The following is a description of a gene set: studied in species Homo sapiens from publication Chaussabel D, Semnani RT, McDowell MA, Sacks D, Sher A, Nutman TB (PMID 12663451) Monocyte-derived dendritic cells (DC) and macrophages (MΦ) generated in vitro from the same individual blood donors were exposed to five different pathogens, and gene expression profiles were assessed by microarray analysis. Responses to Mycobacterium tuberculosis and to phylogenetically distinct protozoan (Leishmania major, L. donovani, Toxoplasma gondii) and helminth (Brugia malayi) parasites were examined, each of which produces chronic infections in humans yet vary considerably in the nature of the immune responses they trigger. Human Gene Set: GSE360_LOW_DOSE_B_MALAYI_VS_M_TUBERCULOSIS_DC_DN Genes down-regulated in comparison of dendritic cells (DC) exposed to 5 worms/well B. malayi versus DC exposed to M. tuberculosis, and this is the list of marker genes: BRD4, BIRC3, FCGR3B (Fc gamma receptor IIIb), CCT2, PPP2CB, YKT6, H2BC21, ADAR, PLAUR, LDHA, ICAM1, NPRL3, SSB, PLSCR1, GNA15, RALA, LCP1, HSPA5, ANKRD12, OAS2, RBCK1, TNIP1, RND3, ADGRE1, IER3, KYNU, FLT1, MAD2L1BP, CD27, MT1B, GNRH2, CRHR2 (NCBI Gene Id 1395), RFTN1, DENND5A, MX2, UBE2S, MPZL2, ATP2A2, PLA2G7, MMP9, MPDU1, N4BP1, MT1G, TUBB2A, WIPI1, CXCL5, TNFSF14, TRIM38, CCL25, CDK3, DYNLL1, TSPOAP1, HSPA1A, TYMP, MAP2K3, CD47, NRP2, RHBDF1, PEX1, PDE4D, LY6E, RNASE4, NDRG1, PPP1R15A, HBEGF, VAMP5, PRRG1, CUL1, SQLE, PDPN, IFRD1, IFIT2 (interferon induced protein with tetratricopeptide repeats 2), CD48, RIT1, RAPGEF2, ATP6V0E1, SMURF2, DHFR, RRBP1, AASS, SLC22A4, WTAP, CDC42, AK4 (adenylate kinase 4), GPC4, HSPA8, LHFPL2, IL2RG, CCL3 (C-C motif chemokine ligand 3), DTX4, MT2A, S100A8, IL2RA, BASP1, PSMD2, TRIP10, LCP2, CCR7, APBA3, C3AR1, TXN, DENND3, BCL2A1, ALDH1A2, GPD2, CDH1, CCRL2, IL10RA, RBM14, ATF3, GBP2, TSFM, CCL2, PNP, NME1, STOM, MARCO, SLAMF1, CRIM1, INHBA, TFIP11, ELL2, IFI44, SPINK4, BST2, OASL (2'-5'-oligoadenylate synthetase like), SH3BP5, CASP5, AMHR2 (NCBI Gene Id 269), CETN2 (centrin 2), SLC31A1, DUSP1, MYD88, MT1X, CD83, CTSL, CYBB, FSCN1, FANCL, ALAS1, PIM1, GMPR, PFKFB3, RRH, LTK, CYB5A, GJB1, BAZ1A, WARS1, RER1, PLXNC1 (plexin C1), PSMA3, TRAFD1, PLCH1, TRIM21, UBE2L6, ARID1A, MUC6, H2BC12, DUSP5, GLUL, PDE4DIP, FGFR2, TESK2, LITAF, CCL7, GEM, MMP12, SERPINA1, EIF4E2, B3GNT2, MT1E, PAX8, PAIP2B, TRADD, NCBP1, CA12, TFRC, TUBB, TUBB3, DNAJC3, CD163, SEC13, RCAN1, IL3RA, G0S2, DNAJA1, RNF19B, ANXA2, ITGB3, CFLAR, NBN, STAT2, STAT3, ATF5, CSF2 (colony stimulating factor 2), THOC2, S100A9, CIR1